Given this list of marker genes STAT5B, KRAS, FLT3, UBC, ABL2, NRAS, GRB2, FLT3LG, CBL, HRAS, PIK3CA, PTPN11, UBB, FOXO3, PTPRJ, BCL2L11, SOS1 (NCBI Gene Id 7838), AKT2, AKT1, HCK, LCK, CDKN1B, SOCS6, CSK, RPS27A, FYN, STAT5A, GRB10, SLA2, AKT3, GRAP2, SYK, PIK3R1 (NCBI Gene Id 5295), SH2B3, UBA52, SLA, SOCS2, GAB2, here is a description of the gene set: Human Gene Set: REACTOME_FLT3_SIGNALING studied in species Homo sapiens FLT3 Signaling